The following is a description of a gene set: from publication Tabula Muris Consortium (PMID 32669714) Mouse Gene Set: TABULA_MURIS_SENIS_PANCREAS_PANCREATIC_ALPHA_CELL_AGEING studied in species Mus musculus, and this is the list of marker genes: Tle5, Calm3, Prss2, Arglu1, 4933434E20Rik, Ptma, Cd81, Prss3b, Fth1, Srsf5, Lgals3bp, Cotl1, Rnase1, Sycn, Myl6, Sez6l2, Cfl1, Sdc4, Nfil3 (nuclear factor, interleukin 3, regulated), Tmed9, Cirbp, Ppy, Dusp1, H1f2 (H1.2 linker histone, cluster member), Copz1, Tuba1a, Jund, Inpp4a, Psmc2, Psmc4, Tubb5, Eef1b2, Sod1, Fkbp8, Mapre3, Rack1, Rps3a1, Ptov1 (prostate tumor over expressed gene 1), Rbm26, Rps4x, Hsp90aa1 (heat shock protein 90, alpha (cytosolic), class A member 1), Snhg11, Ece1, Arf1, Gnb1 (NCBI Gene Id 99986), Trem2, Ssr1, Ifi27, Cpb1, Tomm40, Mrps12, Fos, Hhatl, Rpl14, Selenos, Kdelr1, Cldn4, Cela2a, Prkaca, A330076H08Rik, Cdkn1a, Klf4 (NCBI Gene Id 269540), Rpl6, Rpl13a, Itm2c, Stub1, Cpa1 (carboxypeptidase A1, pancreatic), Steap4, Scgn, Pcsk1n, Dpysl2, Cela3b, Krt8, Pcbp1, Ier2, Clic1, Btg2, Cox7a2l (NCBI Gene Id 20463), Ctrb1, Pnlip, Sf3b2, Rpl4, Fosb, Ube2s, Rbm39, Igsf9b, Eef1a1, Qpct, Hmgn2, Clps, Atf3, Tubb4b, Xbp1, Calm2, Cox6c, Eif5a, H3f3b, Reg1, Ubc, Rasd1, Ubb, Map1lc3a, Tsc22d1, Klf2, Try4, Ccnd2, Pebp1, Cela1, Ubb-ps, Rpl13, Tbcb, Junb, Jun, Rps3, Slc25a3, Tob1 (NCBI Gene Id 22057, transducer of ErbB-2.1), Emc10, Ctrl, Krt18, Arhgdia, Kdm6b, Dbpht2, Ppp1r15a, Rplp0, Try5, C2cd4b, Herpud1, Ptms, Pyy, Tra2b, Cpa2, Bsg, Zfp36, C1qa, Sfrp5, Ddc, Pnliprp1